The following is a description of a gene set: To obtain insight into the genetic basis of the increase of functional activity of memory B cells over time, we compared the gene expression profiles of day 7 and day 40 NP-specific/IgG1 memory B cells, GC B cells and plasma cells in immunized WT mice and naïve B cells, before and after activation in vitro. Human Gene Set: GSE11961_MARGINAL_ZONE_BCELL_VS_MEMORY_BCELL_DAY40_DN Genes down-regulated in marginal zone B cells versus day 40 memory B cells. studied in species Homo sapiens from publication Kaji T, Ishige A, Hikida M, Taka J, Hijikata A, Kubo M, Nagashima T, Takahashi Y, Kurosaki T, Okada M, Ohara O, Rajewsky K, Takemori T (PMID 23027924), and this is the list of marker genes: MAFG, FBXW8, PTGES2, NDFIP2, ZNF7, SMIM7, PDSS1, ACD, TSR3, GPR155, SLC16A10, RUVBL1, FANCD2, SEPTIN11, FIRRM, POC1A (POC1 centriolar protein A), SPP1, PDE3B, PMS2, NUDT1, CD27, TBC1D12, GPX8, COMMD5, ZFAND2A, LSM2, PRMT3, KLRC3, AGPAT3, WDR83, CETN2, CGRRF1, EIF3B, NBAS (NCBI Gene Id 51594), DAP (NCBI Gene Id 1611), SLTM, CERS4, USP24 (NCBI Gene Id 388634), WDR3, MPLKIP, P4HB, TNFSF14, SLC12A7, ALDH1L2, LIMK2, PRKAB1, RIOK1, WWOX, PMF1, ACLY, METTL26, POLRMT, CCL4, ANXA2, DGKA, HEMGN, ATP8B4, RFC4, DNAAF2, UTP4, MOXD1, ACP6 (acid phosphatase 6, lysophosphatidic), SKAP1, SIMC1, TATDN2, POP1, HINT1, CRACDL, NME7, MANF, PEX14, MLH1, GFM1, GTF3C1 (general transcription factor IIIC subunit 1), PASK, TPST2, KIAA1958, ABRACL, GLE1, ZNF598, MS4A15 (NCBI Gene Id 414353), GPX7, ITGB3BP, CTSW, KRT34, ZNF512, FAM81A, NHP2, TXN2, EIF1AD, ETS1, PRRC2B, PPP2R1A, DDOST, HMCES, LONP1, NRARP, SSRP1, SLC2A12, WDR75, SAMM50, SYNE2, DHX36, P3H4, PADI2 (NCBI Gene Id 11240), CTNNAL1, PPP1R37, ARV1, MR1, EIF2B5, KDM4D, SMPD4, GPR174, SNHG17, GPR171, FHL2, F2RL1, DANCR, IGF2R, FAM78A, TXNL4B, NDUFAF4, TRRAP, SGCE, EIF2D, GSPT1, GARS1, SLC7A14, CKS1B, ELAC2 (NCBI Gene Id 60528), RANBP10, PGLYRP2, CTPS1, MCM6, CNPY4, CDK4, CD28, CD247, PHACTR3, ERI2, CTBP2, SHMT2, DDX31, TTI2, AGTPBP1, OSBPL3, CMKLR1, LGALSL (NCBI Gene Id 29094), LZIC, LGALS1, DENND2B, UGCG, SLCO2A1 (solute carrier organic anion transporter family member 2A1), THSD4, PSME3, HACD1, TACC3, KCNU1, MINDY2, BTBD19, SUSD1, ATAD3A, TMEM41A, RCC2, GAB3, GMDS, WDR89, MYB, TMEM97, BLTP3B, TELO2, MON2, IRF8, NT5C3B, CIPC, SCTR, PPIL6, MLEC, NOP56, NELFA, EBNA1BP2, MKI67, HJURP, TRIM68, ANKRD46, ATG16L2, MEX3D, MOGAT2, PPP2R2A, RNASE1, PIGY, MIEF1, LRP6, KCTD1, DHX16, INAFM1, LTV1, NUCB1, SLC35D1, RLF